The following is a description of a gene set: Stem cell factor (SCF) is a growth factor with membrane bound and soluble forms. It is expressed by fibroblasts and endothelial cells throughout the body, promoting proliferation, migration, survival and differentiation of hematopoetic progenitors, melanocytes and germ cells.. The receptor for SCF is KIT, a tyrosine kinase receptor (RTK) closely related to the receptors for platelet derived growth factor receptor, colony stimulating factor 1 and Flt3. Four isoforms of c-Kit have been identified in humans. Alternative splicing results in isoforms of KIT differing in the presence or absence of four residues (GNNK) in the extracellular region. This occurs due to the use of an alternate 5' splice donor site. These GNNK+ and GNNK- variants are co-expressed in most tissues; the GNNK- form predominates and was more strongly tyrosine-phosphorylated and more rapidly internalized. There are also splice variants that arise from alternative usage of splice acceptor site resulting in the presence or absence of a serine residue. Finally, there is an alternative shorter transcript of KIT expressed in postmeiotic germ cells in the testis which encodes a truncated KIT consisting only of the second part of the kinase domain and thus lackig the extracellular and transmembrane domains as well as the first part of the kinase domain. Binding of SCF homodimers to KIT results in KIT homodimerization followed by activation of its intrinsic tyrosine kinase activity. KIT stimulation activates a wide array of signalling pathways including MAPK, PI3K and JAK/STAT. Defects of KIT in humans are associated with different genetic diseases and also in several types of cancers like mast cell leukaemia, germ cell tumours, certain subtypes of malignant melanoma and gastrointestinal tumours. studied in species Homo sapiens Reactome Pathway: Signaling by SCF-KIT part of: Signaling by Receptor Tyrosine Kinases, and this is the list of marker genes: SOS1 (NCBI Gene Id 7838), PTPN11, FER, KITLG, VAV1, STAT1, LYN, KRAS, PIK3CA, STAT3, FYN, CHEK1 (NCBI Gene Id 1111), PIK3R3, GRB7, GRAP2, PTPRU, STAT5A, NRAS (NCBI Gene Id 4893), HRAS, STAT5B, SOCS1, SOCS6, KIT, FES, RAC1, GAB2, GRB2, YES1, PIK3R2, SH2B2, SH2B3, PRKCA, CBL, CMA1, SRC, GRB10, TEC, MMP9, LCK, JAK2, PIK3R1, GRAP, PTPN6